Given this list of marker genes CHRNA9, CHRNA1, CHRNB3, CHRNA3, CHRNA2, CHRNB4, CHRNA4, CHRNB2, CHRNA7, CHRNA6, CHRNA5, here is a description of the gene set: species: Homo sapiens Human Gene Set: REACTOME_HIGHLY_CALCIUM_PERMEABLE_POSTSYNAPTIC_NICOTINIC_ACETYLCHOLINE_RECEPTORS Highly calcium permeable postsynaptic nicotinic acetylcholine receptors